The following is a description of a gene set: Genes predicted to be targets of miRBase v22 microRNA hsa-miR-6809-3p in miRDB v6.0 with MirTarget v4 prediction scores > 80 (high confidence targets). species: Homo sapiens Human Gene Set: MIR6809_3P from publication Chen Y, Wang X (PMID 31504780), and this is the list of marker genes: COPG2, MEF2A, PDE4D, ZNF426, FBXO47, HTR5A, KDM7A, RBMS3, PRTG, EPAS1, PALM2AKAP2, ZNF268, RB1CC1, XIAP, SYNPO2, KNL1, NTN4, RGS5, NLRC3, HOXC8, CHRM2, POU2F2, ZCCHC7, TACC1, FBXO11, PDGFRA, ALKBH8 (NCBI Gene Id 91801), SMC1B (NCBI Gene Id 27127), BLTP2, FRMD7, CD84, AAK1, ARID5B, ABCC9, DTNB, YPEL2 (NCBI Gene Id 388403), ZBTB2, CDCP1, VANGL1, ZNF594, SPTSSA, PRR27, ZNF559-ZNF177 (NCBI Gene Id 100529215), CPEB4, NPEPPS, LTN1, MEX3A, FOXN3, SEMA6D, TFDP2, PIP5K1B, GRP, PAWR, DCLRE1C, MEGF10, SLC38A1, ERBB4, PPP4R3A, FAM110B, CHML, CDKL2, LRP8 (LDL receptor related protein 8), UTRN, PDZRN4, CEP85L, PYURF (PIGY upstream open reading frame, NCBI Gene Id 100996939), SETD9, PKDREJ, AMD1 (NCBI Gene Id 262), REEP1, DCAF5 (NCBI Gene Id 8816), STXBP6, RCN2, PCDHA9, FANCL, FGD6 (NCBI Gene Id 55785), ZBTB20, ATP8A1, TMTC1, B3GALNT2, SMIM10L1, TRIM6, BLOC1S6, HPCAL4 (hippocalcin like 4), LYRM2, ZNF514, KIAA1586, HNRNPU (NCBI Gene Id 3192), INPP5A, FMO5, USP37, RASAL2, SMAD5, ITGB6, ZNF813, ZNF578, IGF2BP2, GPRASP3 (NCBI Gene Id 80823), MBOAT2, BDP1, PCDHA12, MCFD2, BNC2 (basonuclin zinc finger protein 2), CCDC14, ESRRG, RNF169, KMT5B, MAP6D1, ZNF676, HEXIM1, SARM1, NLN, GRIP1, MBLAC2, SLC35F3, GCNT1, NFATC2, LRRC1, KMT2C, CREB5, IL17RD, ZNF460, EPHA7, ZNF117, TLE1, STXBP3, MAGEA4, ANGPTL3, GALNT15, HMGB3, ZNF704, SIK3 (SIK family kinase 3), FZD10, STX16, PCDHA6, AGPAT3, ZFP1, DCT, PTCD2, SH3PXD2A (SH3 and PX domains 2A), ACSM2B, PCSK2, AMIGO1, PCDHA11, ZMYM4 (zinc finger MYM-type containing 4), B3GLCT, TBL1XR1, ZNF705EP, IDE, CACNG2, TMEM87A, STON2, ZNF28, AATK, PCDHA8, RAB27B, PLAGL2, ARHGAP6, PMEPA1, HAO1, TRPC5, VTCN1, RAB3B, MGP, IKZF2, IKZF1, PPP1R1C, PAPPA, MID1, LSM3 (LSM3 homolog, U6 small nuclear RNA and mRNA degradation associated), QRFPR, AIMP1, PEX5L, SLAIN2, C14orf132, ZMAT1, DDX6, LPP, AXIN2, HS6ST3, RAD51B, ARRDC4, TAF1B, GML, CCDC186, CCDC141, TMEM254, PAPSS2, PACRGL, EIF1AY, ZNF737, PAK2, CDK12, EPS8, THRAP3, USP47, ADARB2 (adenosine deaminase RNA specific B2 (inactive)), ZKSCAN1, NAV2, NIPSNAP3B, FAM53B, ASH1L, TBCEL, NFXL1, PTPRS, KCNRG, SEMA3C, DNAJC27, SPARC, ATF3, ZNF440, RBMS1, PTBP1, BAG5, PCDHA7, GAS2L3, DGKH, MAF, TRIO, ZNF701, SOCS7, ZNF730, GRIK2, ADAMTS6, TMEM199, LARP4, PALS2, FBXO32, GXYLT1, ADAMTS5, ELAC1, ZNF705A, RAPH1, SETDB2, SELENOI, MFSD8, WDR33, RCBTB2, JADE2, GPR158, DAZAP1, MEIS2, ARHGAP24, ALDOB (NCBI Gene Id 229), ERG, ACVR1C (NCBI Gene Id 130399), ZNF124, GUCY1A2 (guanylate cyclase 1 soluble subunit alpha 2), ZNF90, FAM78A, OARD1, PHLDA1, TSC22D2, DNMT3A, ZC3HAV1, MTMR1, TTC14, SEPTIN7, CDON (cell adhesion associated, oncogene regulated), CDR2L, CNOT6L, HIC2, PPP1R9A, CTCFL (NCBI Gene Id 164279), FOXN2, SPATA13, FABP7, ZNF567 (NCBI Gene Id 163081), BCOR, CCDC50, SLCO1B3, ADAM10, SLC39A8 (solute carrier family 39 member 8), TENM1, DPY19L4, SPTSSB, KIF2C, CDK6, ITPKB, KCNQ3, STAP1, KLHL18, PLXNA4, ZNF765, ZNF746, DRAM2, SOBP, STUM, OSBPL3, PRDM16, GREM2, ZNF385D, ZNF493, LDB2, SLC5A12, KALRN, TDP2, ZNF718, SNX1, SLC25A24, ENTPD4, PURA, GPR3 (NCBI Gene Id 2827), USP12, ANPEP, CLEC16A, FZD3, RPIA, GORAB, NHLRC2, ZNF189, CADM2, EPHA8, BTBD1, AFDN (afadin, adherens junction formation factor), TOB2, PCDHA13, FFAR4, ZFP36L1, TMEM35A (transmembrane protein 35A), FAM222A, LINC02907, CFLAR, MAP7, TET1, ZNF763 (zinc finger protein 763), KLHL29, KLF12, ZNF721, LOX, TCERG1, ATG5 (autophagy related 5), PAK1, NUDT3, LCORL, ZMYND8, SLK, TAB3, EGR3, THBS1, GPATCH2L, HAND1, CREG1, FANCM, TWIST1, SETBP1, BST1 (NCBI Gene Id 683), ZNF716, SHISA6, RTF1, MFSD4B, MYT1, ZFP90, PI4K2B, RNF217, SH3KBP1, EDIL3, WBP2, TBC1D23, HDGFL3, MYCT1, BCL11A, ZNF655, IFI44L, ADIPOR2, ST6GALNAC5, CNOT2, ABLIM1, ZNF106, PCDHA2, RIT1, DDX4, LSAMP, ZNF468, INO80D, MERTK, ERC1, ACP7, ZNF543, CCSER1, PHC3, DET1, PFKFB2, LRRC7, ATG4C, MDM2, GPRIN3 (GPRIN family member 3), ZNF138, MSI2, PSMB1, SCAI (suppressor of cancer cell invasion), SLC8A3, RDH12, PDLIM5, DPY19L2, MAGI3, BMP2, CCDC43, DNTT (NCBI Gene Id 1791), ANO3, PPP6R3, ZNF107, PHYHIPL, ZNF479, KPNA6, SLC10A1, SLC36A4, CNR1, ZNF559, STOX2, ZNF761, NEK9, DLG3, MESD, EVC, RPS6KA6, ZNF808, STRBP, ALDH2 (NCBI Gene Id 217), PHF1, KRIT1, SNX14 (NCBI Gene Id 57231), TMEM170B, PDE5A, ZNF99, ZNF195, FAM120A, LCTL, RSBN1, MAGEA12, BHLHE40, KIF5B, MTX3, SERTAD2, TRIM71 (NCBI Gene Id 131405), ZNF844, MBNL3, SLC1A1 (solute carrier family 1 member 1), TMEM14C, GSK3B, PURB, PTER (NCBI Gene Id 9317), C22orf46P, MINDY2, EHD4, PCDHA4, TBL1X, GAREM1, GRHL2, CUL3, GIPC2, DSCAM, RNF6, HPSE2, NCKAP5, PCDHA1, SLC7A14, VSTM2A, MEX3B, EP400, VGLL3, FBXL17, DPH3, YTHDF2, ZNF439, PYGO1 (pygopus family PHD finger 1), SEC11C, NIPBL, FAT3, NEDD4L, FYB2, FOXI1, PCDHAC1, DOCK10, PIN4, TMEM178B, COX10, PCDHAC2, SLC9A6, ZBTB1, PTPRB, CRH, GREB1, CERT1, SRR, RALYL, RPS10-NUDT3, TET3, TRIM8, PPP2R2A, UNC5D, SAMD5, TDG, MICAL3, NOVA1, DCUN1D5 (defective in cullin neddylation 1 domain containing 5), ZNF136, CPM, PCDHA3, CMTM6, SGCD, PCDHA10, ONECUT2, CDKN2AIP, DEUP1, DCX, SLFN13, ORAI1, CALHM5, ENC1, HOXB4, ESRP1, ZNF257, PPP1R42, CASC3, CASK, MCU, ZDHHC3, GAD1 (NCBI Gene Id 50977), KLHL5, XRCC4, VDAC3, MYRIP, COL11A2, ZNF175 (NCBI Gene Id 7728), SNX18, HIVEP2, FAM81A, ZNF682, KMT2A, MEFV, PTGER4, ZNF326, TNRC6B, WASHC4, CHMP1B, DIP2C, ENPEP, ZFAND3, RHOA, SNX27, SLA, RBM20 (NCBI Gene Id 282996), SLC25A17, ZNF208, CTNNA1, ARFGEF3, ZNF705D, MS4A2, NTRK2, PAM, PCDHA5, SP3 (Sp3 transcription factor), UBE2QL1, CUL4B, TREML4, ADAM7, ZNF302